Given this list of marker genes Poll, Pold1, Pcna (NCBI Gene Id 18538), Pole, Polb, here is a description of the gene set: species: Mus musculus Mouse Gene Set: GOBP_BASE_EXCISION_REPAIR_GAP_FILLING Repair of the damaged strand by the combined action of an apurinic endouclease that degrades a few bases on the damaged strand and a polymerase that synthesizes a 'patch' in the 5' to 3' direction, using the undamaged strand as a template.